The following is a description of a gene set: studied in species Homo sapiens Glycosylation and related congenital defects Human Gene Set: WP_GLYCOSYLATION_AND_RELATED_CONGENITAL_DEFECTS, and this is the list of marker genes: MAGT1, MOGS, ALG14, ALG12, MPI, ALG8, DPM1, ALG11, DOLK, TUSC3, ALG2, DPAGT1 (NCBI Gene Id 1799), B4GALT1, ALG13, MGAT2, DPM2, PMM2, MPDU1, ALG6, ALG3, GMPPB (GDP-mannose pyrophosphorylase B), ALG9, ALG1, SRD5A3, DPM3